Given this list of marker genes TMOD3, MTMR2, H2AC25, FUNDC2, AMPD3, ZNF263, PIK3R5, IL4R, RCBTB2, ZFP36L2 (ZFP36 ring finger protein like 2), ATP1B1, CCR7, RNF24, DNAI4, POLR3GL, C2orf68, PGLYRP2, IGIP, CHD7, RUNX3, DENND6A, CD7, LEMD3, PMEL, UQCC5, CFL2, PTK2, TRIB2, WASL, STAR, MAML1, IER5, SIK1, TMEM108, RC3H1, PACC1, PPP1R18, ZBTB4, MREG, SGK1, FAM13B, UBR1, CFLAR, MNT, ZNF652, LENG1, TCF20, PAG1, RALGPS2, PHF2, CNN3, THAP12, SAMD8 (sterile alpha motif domain containing 8), FOXP1, EEF2K, ATP8A1 (NCBI Gene Id 10396), PPP1R3F, ITM2A, PTGER4, GPR183, CDKN1B, MAP2K7 (mitogen-activated protein kinase kinase 7), ALG2, CA2 (NCBI Gene Id 760), H3C14, ZBTB49, IFT80, CALCRL, RPS16, RCAN3, CTDSP1, DZIP1, SERAC1, PSD, BTG1, MRPL30, PBX2, SEMA4B (semaphorin 4B), SMURF1, ZNF471, LRRC39, BTG3, IL7R, SESN1, ADD3, SLC25A27, NR1D2, ARID1A, VIPR1, RFLNB, CCDC73, IFNGR1, EEIG2, TRIM56, SATB1 (SATB homeobox 1), PPP2R5A (NCBI Gene Id 5525), PADI2 (NCBI Gene Id 11240), XPO4, CD2AP, BAMBI, LFNG, RREB1 (ras responsive element binding protein 1), TP53BP2, PPM1B, GPR146, ENC1, SMC6, PIK3IP1, MAP4K3, ZNF354C, DIPK1A, DENND2C, NEXN, USP12, LATS1, VPS37B, ACBD3, NRIP1, BBX, ATP10D, RUNDC3B, RRAS2, PPP3CA, EEIG1, DDX3X, YAE1, IMPDH1, AUH, ZFP1, BICD2, ATP11B, COL11A2, FAM78A, CNST, UST, GALNT6, EEF1D, IL6ST (interleukin 6 cytokine family signal transducer), TET1, AMZ1, ALDH2, CREBRF, ATN1, MIER1, CLCN6, RASSF3, PKD2L2, GM2A, RARA (retinoic acid receptor alpha), HID1, BCL11B, LAIR1, PPARGC1B, SPATA6, PATJ, TRAF4, TSR2, NFRKB, ITGA6, SMAD4, RPS23, AGO1, IL27RA, PRR22, CAMK1D, GATAD2B, CARD6, KLHDC1, PRKD3, ADGRL1, RPP40, ARID3B (NCBI Gene Id 10620), VOPP1, NCOA2 (NCBI Gene Id 10499), NR3C1, SH3PXD2A, MOSMO, FNDC10, MECP2, ACSS1, AMER1 (NCBI Gene Id 160176), TOP2B, BASP1, ZBTB40, TMEM64, PARD6G (par-6 family cell polarity regulator gamma), MTURN, IRF2BPL, CD226, DDX5, GATA1, IFIT2, TDRP, VCAN (NCBI Gene Id 7902), GALNT10, AAK1, GAPVD1, RRAD, PEX19, here is a description of the gene set: from publication Miyazawa M, Takashima A (PMID 22974541) Identification of ROS induced genes on dendritic cells Dendritic cells were incubated for 15 min with or without a ROS inhibitor (DPI), washed extensively and incubated for 30 min with a chemical allergen (DNFB), hydrogen peroxide, and vehicle alone in HBSS containing DPI or vehicle. After washed extensively, the samples were post-incubated for 5.5 h with DNFB, hydrogen peroxide, or vehicle in complete culture medium containing DPI or vehicle. Genes up-regulated in dendritic cells: hydrogen peroxide versus diphenyleneiodonium (DPI). studied in species Homo sapiens Human Gene Set: GSE20727_H2O2_VS_ROS_INHIBITOR_TREATED_DC_UP